Given this list of marker genes GATA2, EPB42, ANK1, SLC4A1, PIK3CA, F9, MYD88, DLD, PROC, THBD, HRG, PROS1, HBB, SPTB, AGGF1, F5, SPTA1, here is a description of the gene set: An abnormality of coagulation associated with an increased risk of thrombosis. Human Gene Set: HP_HYPERCOAGULABILITY species: Homo sapiens Hypercoagulability